The following is a description of a gene set: species: Homo sapiens from publication Xie X, Lu J, Kulbokas EJ, Golub TR, Mootha V, Lindblad-Toh K, Lander ES, Kellis M (PMID 15735639) Comprehensive identification of all functional elements encoded in the human genome is a fundamental need in biomedical research. Here, we present a comparative analysis of the human, mouse, rat and dog genomes to create a systematic catalogue of common regulatory motifs in promoters and 3' untranslated regions (3' UTRs). The promoter analysis yields 174 candidate motifs, including most previously known transcription-factor binding sites and 105 new motifs. The 3'-UTR analysis yields 106 motifs likely to be involved in post-transcriptional regulation. Nearly one-half are associated with microRNAs (miRNAs), leading to the discovery of many new miRNA genes and their likely target genes. Our results suggest that previous estimates of the number of human miRNA genes were low, and that miRNAs regulate at least 20% of human genes. The overall results provide a systematic view of gene regulation in the human, which will be refined as additional mammalian genomes become available. Genes having at least one occurrence of the highly conserved motif M69 SGCGSSAAA in the regions spanning 4 kb centered on their transcription starting sites. This matches the E2F1, TFDP1, RB1 transcription factor binding site V$E2F1DP2_01 (v7.4 TRANSFAC). Human Gene Set: SGCGSSAAA_E2F1DP2_01, and this is the list of marker genes: POLD3, TRA2B, CDCA7, VCAN, SRSF1, ZBTB4, KBTBD7, FHOD1, PRPS1, YBX2, TFAP4, ACBD6, FKBP5 (NCBI Gene Id 2289), H3C1, KCNA6, FANCC, BRME1, NRK, PTMA, HNRNPR, NASP, CNOT9, NCL, POLR2A, RET, MAZ, UGGT1, POLA1, ILF3-DT, CDC6, HMGXB4, TRMT2A, ATAD2 (NCBI Gene Id 84325), UBR7, NFATC2IP, PCLAF, BRMS1L, NUP62, PAN2, SMC3, ASXL2, FBXO5, ALDH6A1, ATAD5, NOLC1, ID3, CDC20B, SRSF7, ZNF565, GLRA3, DNMT1, ZNF367, DNAJC9, IER5L, SLC9A5, H2AZ1, EMSY, PIM1, TMEM108, JADE1, HIRA, TOPBP1, MSH5, MCM6, THAP8, MTF2, H4C1, TRIM39, PKMYT1, PAQR4, PRP4K, GEN1, MYH10, PRKDC, FMO4, GMNN, STAG2, HNRNPD, PCIF1, POLE4, H2BC12 (NCBI Gene Id 85236), HOXC10, JADE2, HCN3, SMC6, UNG, ADAMTS2, CASP8AP2, LUC7L3, RPS20, KCNS2, E2F1, ATF5, SNRPD1, PCSK1, DCK, SYNCRIP, NABP2, AP1S1, MCM7, FANCG, PCNA (NCBI Gene Id 5111), PODN, ZCWPW1, SYNGR4, MCMBP, HMGA1, E2F8, H2AC12, POLE2 (NCBI Gene Id 5427), MRPL40, MEPCE, CLSPN (claspin), ARHGAP6, GINS3, CAND1, MCM3, MCM2, MSH2, NR6A1, TMEM143, RANBP1, E2F3, PHF5A, HNRNPUL1, KIAA0825, GATA1, IL4I1, SMC1A, GON7, PHC1, H2AZ2, ACO2, ING3, RIBC1, MYC, ZCCHC8, MXD3, PPM1D, WDR62, ZNF644, SUV39H1, KBTBD6, STT3B, USP37, SMAD6, RAVER1, CTDSPL2, GABRB3, NIPBL, DCTPP1, AP4M1, EED, GPRC5B, ZNF503 (NCBI Gene Id 84858), MCM4, EFNA5 (ephrin A5), TYRO3, CDC25A, TAOK2, PLAGL1, AK2, RRM2, POLD1, WBP2NL, ZNF687, ILF3, STK35, TMEM187, RMI2 (NCBI Gene Id 116028)